The following is a description of a gene set: Any process that modulates the rate, frequency or extent of blood vessel remodeling, the reorganization or renovation of existing blood vessels. Human Gene Set: GOBP_REGULATION_OF_BLOOD_VESSEL_REMODELING studied in species Homo sapiens, and this is the list of marker genes: BCR, TMBIM1, FLT4, MIR27B, TGFB1, CEACAM1, MIR29B1, HRG, MIR20A, MIR17, CST3, MIR143